Given this list of marker genes TGFB1, FKBP1A, TGFBR1, TGFBR2, here is a description of the gene set: Reactome Pathway: TGFBR1 LBD Mutants in Cancer part of: Loss of Function of TGFBR1 in Cancer Mutations in the ligand-binding domain (LBD) of TGF-beta receptor 1 (TGFBR1) have been reported as germline mutations in Ferguson-Smith tumor (multiple self-healing squamous epithelioma - MSSE), an autosomal-dominant skin cancer condition, with tumors frequently showing loss of heterozygosity of the wild-type TGFBR1 allele. Somatic mutations in the LBD of TGFBR1 have been reported in esophageal carcinoma. species: Homo sapiens